The following is a description of a gene set: Human Gene Set: KEGG_MEDICUS_REFERENCE_HIF_1_SIGNALING_PATHWAY studied in species Homo sapiens Pathway Definition from KEGG: HIF1A == ARNT => (SLC2A1,VEGFA,TGFB,PDGFB,TGFA) HIF-1 signaling pathway. Pathway ID: N00079. Pathway type: Reference. Pathway class: nt06264 Renal cell carcinoma., and this is the list of marker genes: PDGFB, TGFB1, VEGFA, HIF1A, TGFB3, ARNT, TGFB2, TGFA, SLC2A1